The following is a description of a gene set: Human Gene Set: GOBP_BROWN_FAT_CELL_DIFFERENTIATION studied in species Homo sapiens The process in which a relatively unspecialized cell acquires specialized features of a brown adipocyte, an animal connective tissue cell involved in adaptive thermogenesis. Brown adipocytes contain multiple small droplets of triglycerides and a high number of mitochondria., and this is the list of marker genes: ADRB3, ADIPOQ, MIR128-1, SLC2A4, FABP4, PRDM16, FABP3, INS, CEBPA, ZNF516 (zinc finger protein 516), BNIP3, RREB1, EBF2, ADRB1, GATA2 (GATA binding protein 2), VSTM2A, TFE3, ADIG, BMP7, LRG1, PLAC8, ZBTB7B, PEX11A, METRNL, LAMB3, HNRNPU, NAPEPLD, FTO, SH2B2, LEP, TRPV4, CEBPB, DUSP10, PTGS2, PPARGC1A, MAPK14, PIM1, ERO1A, ADRB2, FNDC5, ALDH6A1, RGS2, ARL4A, FFAR4, SOX13, FLCN, SIX1, SLC39A13, SIRT1, UCP1, MB, NUDT7, SLC7A10 (solute carrier family 7 member 10)